The following is a description of a gene set: Catalysis of the transfer of a phosphorus-containing group from one compound (donor) to another (acceptor). Human Gene Set: GOMF_TRANSFERASE_ACTIVITY_TRANSFERRING_PHOSPHORUS_CONTAINING_GROUPS studied in species Homo sapiens, and this is the list of marker genes: PLK3 (polo like kinase 3), TAOK3, MYO3B, SELENOO, HK1, PAK4, CMAS, STK38L (serine/threonine kinase 38 like), AVP, NRBP1, MAPK6, ACVR1C, ADCK2, STAP1, RIPK3, NRP2, TLK2, GK, ULK2, PCYT2, MARK3, LRRK2, SPRED2 (sprouty related EVH1 domain containing 2), NMNAT3, RPS6KB2, LTK, CCNH, NT5C2, TAOK1, NEK9, TRPM7, ITK (IL2 inducible T cell kinase), MAP3K11, ANKLE2, ABL1, POLK, PRKDC, MAP3K7, TOP1, NMRK2, PKIB (NCBI Gene Id 5570), TKFC, CKS2, CHRAC1, ERCC6, PMS2P11 (NCBI Gene Id 107161145), HK2, AKT1, CLP1, RICTOR, GMFB, DGKD, GCN1, GSKIP, SIRT4, DPAGT1, ETAA1, WNK3 (NCBI Gene Id 65267), CCNC (cyclin C), RPS6KA1, STK19, PAPOLG, GRK6, PTDSS2, TP53RK, CCL2, PANK1, HIPK1, GMPPB, CHEK1, CDK16, PIK3R1, SH3BP5L, WARS1, GALK2, CDC42BPG, MAP4K1, IRAK3, PKM, HYAL2, PHKG2, TPK1, TCL1A, IQGAP1, ROCK1, KLF4, JAK3, MAP4K2, PARP14 (NCBI Gene Id 54625, poly(ADP-ribose) polymerase family member 14), PIGN, SCYL2, EPHB6, CDKN2B, POLE, SGMS2, TRPT1, MAP3K14 (NCBI Gene Id 9020), DYRK1B, AASDHPPT, FLT3, SLC27A1, SRPK3, TEP1, TENT5A, MPP1, CSNK1G3, ACVR1B, LILRB4, DCAF1, GREM1, PIP5K1B, POLE2, CAMK1G, STK3, AKT2, PIM2, SRPK1, CXCL10, GDF10, LATS2, TESK1, CKB, AAK1, CIB1, NME2P1, NEK2, PAN3, LIMK2, IRAK1, DTYMK, YWHAB, STK11, ITPK1, BRDT, PIGG, NME1, NCKAP1L, PIM3, MUSK, POLR3B (RNA polymerase III subunit B), PAK2, PDIK1L, CSNK1A1L, CCL5, PANK2, TEX14, WNT11, ATG13, TSSK6, PMS2P1, MAPK13, SH3GLB1, MAPK1, PRKAG1, CDKL2, PDXK, CAMK2D, HK3, MAP3K6, DLG1, POLR1D, MTOR, PRKACB, POT1, TEK, NTRK3, TCL1B, UAP1, RAD50, NMRK1 (nicotinamide riboside kinase 1), YRDC, AK5, PRKRA, DKC1, RIOK3 (RIO kinase 3), BCR, MMD, DOLK, TESC, XYLB, TWF1, ANKK1, LAMTOR3, HSP90AB1, PIP5K1C, CKMT2, RAF1, GPRC5A, PARP16, MAPRE3, PLK1, CSNK2A3, PIK3R2, EPHB2, MAPKAPK3, ACSL1, PARP4, MSTN, CCNE1, PRKAG3, ABI1, MAPK8, AKT1S1, PINK1, TERF1, PIK3R3, NTRK2, BMPR1A (bone morphogenetic protein receptor type 1A), GSK3B, CDKL5, TAMM41, STK16 (NCBI Gene Id 8576), CSNK1D, PPM1D, DUSP19, PRKAA2, TUT4, ERBB2, BMX, REV1, DAZAP2, MAP2K3 (mitogen-activated protein kinase kinase 3), RANBP2, PANK4, STK35, CERKL, CDKN1A, CCNA1, POLR2J, MAP3K9, WNK4, PRKCA, BMP7, RET (ret proto-oncogene), PTK6, POLR2E (NCBI Gene Id 5434), MOCS3, POLR2F, CHP1, CEP43, SYK, ALPK1, QARS1, FKTN, EPHA8, CSNK1A1, ART5 (ADP-ribosyltransferase 5), CDK4, MAPK8IP2, TRIM24, WNK1, MATK (NCBI Gene Id 4145), CTU1, CCNK (NCBI Gene Id 8812), POLD3, AXL, SPHK2, PAPSS2 (3'-phosphoadenosine 5'-phosphosulfate synthase 2), DEPTOR, RHOH, BRD4, PARP9, NTRK1, CDK14, CSF1R, SBK2, AJUBA, ART3, CALM1 (calmodulin 1), SEPHS1, DDX3X, STK40, GUCY2F, PRKD1, CD24, FAM20A, MAP4K4, CCNI2, PGK2, PGS1, PDK3, EPHA5, BLK, MT3, DAPK3, NPR1, ATAD3A, PFKFB3, AK7 (adenylate kinase 7), PTDSS1 (phosphatidylserine synthase 1), MLKL, AMHR2, CAMKK1, GDPGP1, DGKZ, CAMK2B, POLR3C, EPHA6, UHMK1, UGP2, PKLR, DUSP22, FERMT2, THG1L (tRNA-histidine guanylyltransferase 1 like), NAGK, PARVA, ABL2, CEPT1, AK9, PHKA1, PIF1, IP6K3, POLR2L, PIK3CD, NRG1, MAST3, CCNL2, CARD11, PGK1, CAMK2N2, NUAK2, PARP11, RPS6KA4, CTU2, SMCR8, FN3K, CDK19, PPP1R1B, GMFG, SAMD15, NPR2, SMO (smoothened, frizzled class receptor), DGKI, PRKD2, POLR1H, NMNAT1, CDK3, DDR2, CDK5R2, PASK, PDGFRA, CDK1, TNKS1BP1, FER, RASSF2, TTBK2, PARP6, MAPK12, KAT2B, PDGFRB, DELE1, TYK2, PRKCH, DYRK4 (NCBI Gene Id 8798), POLR3H, CLK4, GRK5 (NCBI Gene Id 2869), SRPK2, CDK7, CD40LG, STK36, RACK1, EEF1A1, FYN, ERCC4, MAP3K4, ETNK1, CDK5, CCKBR, CAMK2G, DYRK2, MOB2, INSRR, CDK6, UVSSA, STK24, GAK, CIT, AKT3, CKMT1B, POLE4, WEE1, MTCP1, CDKN2C, TAB1 (TGF-beta activated kinase 1 (MAP3K7) binding protein 1), TUT7, MAP3K20, HBEGF, POLR2H (NCBI Gene Id 5437), PRKG2, MAPK10, SELENOI, TENT2, MOB1B, CCNP, PRKCB, ALDH18A1, OBSCN, PCK1, NGF, CCNB1, CCND3 (NCBI Gene Id 896), LTBP4, TENT5C, PKIA, SNCA (NCBI Gene Id 6622), TNKS, CPNE3, GRK3, MAPK14, CKS1B, LTBP1, LCK, HTR2A, GRK7, COASY, TRIB3, EPO, CSNK2A2, STK32A, ILK, GDF2, MAST1, POLR3F, NME3, DYRK3, PFKP, PANK3, HEXIM2, GK5, STK31, PIM1, AFAP1L2, PFKFB1, BTK, NCK1, CDKL4, EIF2AK4, CHEK2, PTK2B, AHSG, POLR2B, CDKN2A, BMP4, PIK3R4, EFNA4, RPAP1, MNAT1, MOK, EPHA4, PAK1, N4BP2, TENT5D, PAK5, PCNA, MB21D2, TSSK3, SPHK1, STYK1, GRM5, TRIB2, MST1R, UCK1, PRKACG, RPS6KA5, GUK1, POLR2A, POLR3K, SIK1, SGK1, SGMS1, CLK1, EPHA3, SIRT6, MYLK, SAV1, NME9, IL6ST, OAS2, CDK20, NRG3, MAP3K12, STK32B, HUNK, MOS, TTBK1, NRP1, CHUK, FGFRL1, CAMKV, CMPK1, STK17A, CDKN1C, DLG2 (discs large MAGUK scaffold protein 2), ATM, MAP2K2, DAPK2, PI4KB (NCBI Gene Id 5298), BMPR1B, HEXIM1, MVK, MAST4, EPHA10 (NCBI Gene Id 440580), CKM, CAMK1, PDGFRL, MOB3C, CDKN2D, ZAP70, MERTK, MAP3K1, FAF1, FAM20C, DBF4B, TEFM, ERBB4, DGKG, PKDCC, OASL, IRGM, CRPPA, CHPT1, TOM1L1, AURKA, IRS2, EIF2AK2, FGR, MARK2, SRC, MAPKAPK5, NEK5, IBTK, MAPK8IP1, ANKRD42, C8orf44-SGK3, PFKL, POMK (NCBI Gene Id 84197), ROR2, HSPB8, PI4KAP2, RPS6KA3, PAK3, PI4KA, MAP3K2, RPS6KA6, CCL3, PRPS2, PSTK, TESK2, MAP2K1, PAPOLB, MELK, MADD, TSSK2, NIM1K, PNKP, POLQ, PXK, DGKQ, HTRA2, PRKCG, MYLK4, IL2, EEF2K, CDK11B, LRGUK, PRKCZ, AK3, ARAF, NEK8, EPHA2, FGGY, CCNI, HSPB1, MBIP, TK2, ATG14, POLR1C, ERN2, POLD4, NADK, CSNK1E, MARK1, CDKL3, CGAS, PPIP5K1, CDK18, GPRC5B, CDK17, IGF2, CCNJL, SIK2, TRIO, PRKAB2 (NCBI Gene Id 5565), PARP3, FPGT, PDK2, KALRN, CDC7, GRK1, ACVRL1, MINK1, TYRO3, PKN1, FGFR4, PAK1IP1, DGKE, IGF1, SBK3, POLR1A, PRAG1, DDR1, PRKD3, ACVR1, PIK3R6 (NCBI Gene Id 146850), MAP2K7, BUB1, PRPS1, PTK2, MAP3K8, MTPAP, HIPK4, PRIM2, MACROH2A1, SPDYA, UCK2, PEAK1, EFNA3, HSPA5, CHKA (NCBI Gene Id 1119), EIF2AK1, PARP1, WEE2, CDK9, PRKAR2B, PARP12, SGK2, IP6K2, CAMK2N1, G6PC1, PIK3C3, EPHB3, KIDINS220, CSNK2B, PRKACA (protein kinase cAMP-activated catalytic subunit alpha), FLT4, PFKFB4, PCYT1B, POLI, DYRK1A, ALPK3, ERN1, CCNB2, IGF1R, VRK2, KDR, PSKH2, CCNT1, CDKL1, NUAK1, AURKC, ATR, NME6, DGKH, PLK5, ULK1, PRKAR1B, INCA1, GPHN, CLK2, CSNK2A1, TAF1L, CCNJ, DCLK1, TLK1, ALS2, TRNT1, HJV, PIK3CB (phosphatidylinositol-4,5-bisphosphate 3-kinase catalytic subunit beta), LRP6, STK33, BMPR2, PLK2, GYS1 (NCBI Gene Id 2997), PINX1, CDK15 (cyclin dependent kinase 15), CERK, BRD3, RGCC, TERT, TRIM28, SPRY4, CCNA2, PPP5C, RNASEL, PIK3C2B, SBK1, EGF, STRADA, GMPPA, CALM2, SPEGNB, FRK, TOPBP1, NEK6, ACD, POLH, CASK, MAP3K10, TIE1, STK17B (NCBI Gene Id 9262), MAPK15, MKNK2, IP6K1, CDS1, NME2, TJP2, SOCS3, VRK1, NBN, PIKFYVE, AATK, GNPTAB, KSR1, SGK3, TEC, PDPK1, RFK, TPX2 (TPX2 microtubule nucleation factor), PBK, CAB39, RYK, ELP4, ROCK2, PRKRIP1, ITPRIP, GCKR, CRIM1, ALKAL1, PAPSS1, ERBB3, SEPHS2, RBKS, HCK, BRSK2, POLR2I, EIF2AK3, BRSK1, CAMK4, INKA1, DCAKD, PAK6, TRPM6, RSKR, RUBCN, PREX1, NEK4, PPP1R9B, TGFBR2, SIK3, PARP10, PI4K2A, GHR, CIITA, CDC37, PIP5K1A, MAPKAPK2, STRADB, NME7, FKRP, GHRL, MAP3K21, TENT4B, BRD2, TGFBR1, DGKA, TBK1, PRKX, DCLK2, ADPGK, LATS1, EPGN, OXSR1, CCNG2, AK6, GALK1, ITPKA, PKN3, GPRC5D, EPHB4, ALK, STK32C, PRIM1, SPEG, IPPK, JAK1, FES, CAV1, KSR2, MAB21L1, BUB1B, SHPK, NEK1, TERF2, CKMT1A, POLM (DNA polymerase mu), TXK, MYO3A, TENT5B, GRK2, ADCK5, KHK, MAP3K3, CDS2, CNPPD1, MASTL, STK38, PKN2, CCDC88A, PDE8A, MALT1, AK1, HYKK, RHEB, ART1, RIPK4, APC, FGFR2, CDK13, CAMK1D, PDK4, PNCK, RPS6KB1, RPLP1, MED20, INSR, WDR91, DAPK1, MAPK3, CCNT2, REV3L, EPHB1 (NCBI Gene Id 2047), PRKAR2A, PAPOLA, TGFBR3L, PFKM, PIK3C2A, PREX2, CDK8, HTATIP2, HIPK3, FN3KRP, TIPARP, CDK12, MOB3A, PARP15, KIT, PPIP5K2, ACVR2B, CCNQ, MAGI3, SLK, BRAF, HKDC1, SCYL1, DUS2, TAF1, EFNA5, GNE, MAP3K19 (mitogen-activated protein kinase kinase kinase 19), MAP2K6, RIPK2, CMPK2, MAP3K15, DSTYK, MOB3B, POLR3A, DUSP3 (NCBI Gene Id 284066), TUT1, GK2, STK10, CASP3, MAP2K5, MCRS1, TNIK, TNNI3K, PEAK3, PRKG1, GSTP1, MAPK7, LTF, IRAK2, ART4, CCNE2, PMVK, PIK3C2G, NRBP2, MAPK11, PRKAG2, DBF4 (DBF4-CDC7 kinase regulatory subunit), ROS1, PIP4K2C, DCK, PIGF, POLRMT, DDX21, CCNY, PIP4K2A, TGFBR3, CCND2, CDC42BPB, CRLS1, SRMS, SPRED1, POLG, ROR1, NADK2, PIK3CA, POLR3G, AGAP2, AXIN1, LRRK1, MED21, AK4, DMPK, ATP23, MAPK4, LYN, RPS6KA2, FLT1, PRKY, MYLK3, ALPK2, POLE3, EPHA7, CSNK1G1, MAP4K3, ADIPOQ, FGFR3, POLR2K, GPRC5C, PIK3CG, ANGPT4, PPP2R5A, POLA1, CCND1, RIPK1, FLAD1, OAS3, POLB, PRKCD, TTK, PTPRC, SMG1, TERC, ANKRD54, SNRK, PRKCQ, FAM20B, POLR2J2, MMD2 (monocyte to macrophage differentiation associated 2), POLR2C, SAMD8, MYLK2 (NCBI Gene Id 85366), UAP1L1, TRRAP, PPEF2, MAP3K5, GUCY2C, SCYL3 (NCBI Gene Id 57147), NEK7, RPS6KC1, DNTT, FHIT, AURKB, PIK3IP1, YES1, PRKCI, POLG2, ULK4, ADK, PKIG, ADCK1, EGFR, SOCS1, HASPIN, DGUOK, IDNK, SPRY2, CCNB3 (cyclin B3), NUDT5, GYS2, RPTOR, STK25, OAS1, TSSK4, AK8, TREM2, PTGES3, POLR1B, PI4K2B, RNGTT, PDK1, NLK, PRKCE, GCK, STK39, RAC2, TK1, NMNAT2, NEK11, BMP2, MLST8, TGFA, CDK2, VRK3, IGF2R, NME4, GRK4, DAXX, PTK7, TSSK1B, PRKAR1A, IKBKE (NCBI Gene Id 9641), DGKK, PIK3R5, TNK1, PNPT1, UCKL1, GALT, WDR81, MAST2, EPHA1, NEK3, AK2, TRIB1, AREG, SOSTDC1, MAPK9, JAK2, PLK4, PIPSL, CALM3 (NCBI Gene Id 808), AGK, NPM1, TNK2, POLD1, DNAJC3, CDC42BPA, DGKB, PSKH1, WASHC1, CCNF, CCL8, INKA2, SFN, FGFR1, UPRT, TTN, GSK3A, BCCIP, HMGB1 (high mobility group box 1), PRP4K, CCNL1 (NCBI Gene Id 57018), CDIPT, CERT1, CAD (carbamoyl-phosphate synthetase 2, aspartate transcarbamylase, and dihydroorotase), IPMK, MAP3K13, PIP4K2B, TEN1, EREG, POLL, GUCY2D, FCSK, PARP2, MET, ULK3, CDK5R1, GLYCTK, PFKFB2, ITPKC, CAB39L, KARS1, STKLD1, STK26, ALKAL2, CLK3, RIOK2, DCLK3, PIP5KL1, MOB1A, YWHAG, TBCK, ETNK2, MARK4, MAP2K4, LMTK2, EFNB3, TNKS2, CDK11A, CCNG1, BCKDK, IRAK4, VEGFA, PHKG1, NRK, DAB2IP, TENT4A, CSK, PRIMPOL, LIMK1, CDK10, ITPKB, PRPS1L1, PGM2L1, CAMKK2, FICD, BCL10, BAZ1B, CDKN1B, POLN, WNK2, MKNK1, CSNK1G2, IKBKB, ELP3, EFEMP1, LMTK3, PRKAA1, PHKA2, RIOK1, PIGO, CCNO, BTC, POLR2J3, GARS1, CILK1, COQ8B, SH3BP5, PYDC1, FASTK, NEK10, NME5, STK4, BMP2K, NOL9, ACVR2A, CAMK2A, PARP8, PCYT1A, NT5C3A, MAK, TAOK2, COQ8A, HIPK2, PKMYT1, CRCP, TGFB1, MAP4K5, RPS6KL1, CHKB